The following is a description of a gene set: part of: Metabolism of proteins studied in species Homo sapiens Reactome Pathway: Post-translational protein modification After translation, many newly formed proteins undergo further covalent modifications that alter their functional properties. Modifications associated with protein localization include the attachment of oligosaccharide moieties to membrane-bound and secreted proteins (<b>N-linked</b> and <b>O-linked glycosylation</b>), the attachment of lipid (<b>RAB geranylgeranylation</b>) or glycolipid moieties (<b>GPI-anchored proteins</b>) that anchor proteins to cellular membranes, and the vitamin K-dependent attachment of carboxyl groups to glutamate residues. Modifications associated with functions of specific proteins include <b>gamma carboxylation</b> of clotting factors, <b>hypusine formation</b> on eukaryotic translation initiation factor 5A, conversion of a cysteine residue to formylglycine (<b>arylsulfatase activation</b>), methylation of lysine and arginine residues on non-histone proteins (<b>protein methylation</b>), <b>protein phosphorylation</b> by secretory pathway kinases, and <b>carboxyterminal modifications of tubulin</b> involving the addition of polyglutamate chains.<p><b>Protein ubiquitination</b> and <b>deubiquitination</b> play a major role in regulating protein stability and, together with <b>SUMOylation</b> and <b>neddylation</b>, can modulate protein function as well., and this is the list of marker genes: LGALS1, ALG1, RBX1, DCAF4, SCFD1, INO80E, IDE, H4C1, PSME3, L3MBTL2, DCUN1D3, JMJD6, COG3, RAB17, COPB1, RIOX1, ENAM, MUC12, RELA, LYPD8, PSMB10, FBXO40, SNX3, MUC5AC, UBE2D3, TUSC3, HDAC1, USP14, TRAPPC4, DNMT1, F9, FAM20A, PSMB7, MBD1, SATB2, PCNA, LMAN2, CISH, DCAF5, TUBB4B, SPSB1 (splA/ryanodine receptor domain and SOCS box containing 1), NEDD8, BLM, VCPKMT, PENK, PSMA5, LIPT2, TTLL6, DTL, BPIFB2, NUP35 (nucleoporin 35), MAN1A2, NOD2, RAB11B, AR, CNTN5, TRIM13, COPS8, RAB7B, RAB1A, ADAMTS4, AURKB, TUBB2B, B3GNT2, B3GNT8, CDC25A, USP17L4, PALB2, MYSM1, NSF, C1GALT1, CTR9, MAP3K7, ST8SIA4, RNF5 (ring finger protein 5), SBSPON, SCMH1, B3GALNT2, FBXL14, GOSR2, USP42, SPON1, C4A, ALPI, CUL7, CHML, ASB8, TUBA8, DCUN1D4, ST3GAL2, GALNT6, SPACA4, KLHL5, RAB29, PREB, KLHL41, TOP1, FEM1C, GPS1, FBXW8, FBXW9, OS9, SEM1, APOA2, ASB9, FBXW12, ADAMTS7, FBXL22, THBS1, FBXL19, UBA6, GALNT16, SKIC8, ADAMTS8, SVBP, RAB20, VNN1, HGS, FCSK, VDR, NUP214, ZNF350, KLHL22, FBXO2, PSMG3, STAMBP, PPARGC1A, CEACAM7, IL6, MUL1, TECTB, FBXW7 (F-box and WD repeat domain containing 7), DDX5, KLHL20, LYPD1, CUL4A, UBE2D2, PIAS3, SUMF2, YOD1, SEC31B, MBD6, DRG2, TP53BP1, RNF20, LY6H, UBE2D1, NUDT14, ADAMTSL1, PROS1, NOD1, GPAA1, BECN1, SEC23IP, INS, MBTPS1, NUP107, NPM1, FOXK1, SPTAN1, OTULIN, ST8SIA1 (ST8 alpha-N-acetyl-neuraminide alpha-2,8-sialyltransferase 1), PSMD3, TECTA, GANAB, U2AF2, SEH1L, SUMO1, RANBP2, HDAC7, ELOC, TUBA3C, FN3K, RAD52, NCOA1, FOXO4, NSMCE4A, RAET1L, B3GNT9, SENP5, MUC6, SERPIND1, NTNG1, DMP1, USP12, H2AC21, CST3, PSMB6, TAB1, PSMC1, TOPORS, NUP133, ALG2, ACTR8, UBXN7, USP34, APP, COMMD8, RNF40, ADAMTS15, SPTA1, PSMC2, TNFAIP3, FSTL3, NOTUM, ARFGAP3, USP11, COPS3, FBXO15, ALG10B, H2AC11, DYNC1LI2, RAB40C, ULBP2, MUCL1 (mucin like 1), RAB10, BMP15, STAMBPL1, PSMA7, GALNT11 (NCBI Gene Id 63917), MRTFA, FCGR3B, ADAMTS12, H2BC11, PSMD2, BTBD6, DYNC1I2, NUP210, TRIM25, UCHL1, B3GNT4, EDEM1, MUC17, TUBB4A (tubulin beta 4A class IVa), USP17L12, STT3A, TFAP2B, PUM2, HRC, FBXO31, CD59, FGG, NUB1, GFUS, UBE2V2, SKP1, PEX13, USP17L2, RAB41, ASGR2, TRIM28, TTLL5, GP2, HK1, ART4, ASB6, H2BC21, FBXO27, IKBKE, PIGF (phosphatidylinositol glycan anchor biosynthesis class F), DOHH, USP5, LYPD5, MCRS1, GCNT7, WDR5, PSME2, STAG1, MTA1, GPLD1, UHRF2, OTUD7B, PEX12, VNN2, COG6, COG4, MEN1, F7, RAB38, FBXO4, GPC3, MARCHF6, APLP2, RAB3A, ASB16, LY6D, FOLR1, RWDD3, RAB39A, SOCS5, FBXW11, EMID1, OSTC, RAB37, TUBAL3, RAB3C, SLC35A1 (NCBI Gene Id 10559), SMAD7, IZUMO1R, TEX101, TTLL10 (NCBI Gene Id 254173), DCTN4, EVA1A, SUMO2, RAB27B, ARSJ, ABRAXAS2, ST8SIA6, RPA1, GALNT17, ARF5, OST4 (oligosaccharyltransferase complex subunit 4, non-catalytic), ARRB1, SKP2, PEX2, SLC35C1, IGFBP7, MDC1, FGA, GALNT3, ST6GAL2, ST3GAL1, DCAF16, USP13, USP17L17, MITF, UBE2Z, KBTBD6, TNIP3, B4GALT6, SOCS6, GCNT4, PIGU, TFG, OTUD5, RAB33A, UBA2, TBC1D20, ARSL, F10, PSMF1, MUC7, PIGG, DCAF13, UBE2E1, NOP58, MUC3B, SEC22B, RECK, PEX14, MAN1A1, LSAMP, USP19, RNF168, ASB3, USP17L19, DPM2, STX5, TFAP2C, GALNTL6, UBD, SEC22A, H2BC17, ASGR1, TRAPPC2, POMP, GALNT14, ALPL, ATXN3, TRAPPC3, RNF144A, GOLGB1, CTBP1 (NCBI Gene Id 1487), ARSF, ACTR1A, DLAT, EID3, ADAMTS19, STT3B, RAB3D, RNF181, MUC20, USP37, CUL2, UBE2N, ANK1, UMOD, RAB13, SMAD2, RAB3B, RAB1B (RAB1B, member RAS oncogene family), NUCB1, GALNT9, USP22, GRIA1, UIMC1, GFPT1, MUC5B, EPAS1, DCTN1, LYPD4, ARSG, SPSB2, EEF1A1, DERL1, PSMC3, RAB4B, P4HB, DNMT3A, BST1, AGBL3, TDG, RAB21, UBE2T, RNF185, FBXO7, PSMB4, VHL, BARD1, B4GAT1, SPARCL1, H2BC3, ADRB2, FBXO22 (NCBI Gene Id 80234), MLEC, RABGGTB, CHGB, SEC24B, HDAC4, DCAF6, GLB1, THSD4, PMM2, XRCC4, OTUD3, MVD, CAPZA3, BTRC, SPP1, FBXO6, MUC2, C3, ADAMTS14, ABRAXAS1, RAB33B, RNF128, SERPINA10, NUP85, COG8, PROZ, PSCA, USP20, ADAMTS6, MMRN1, MDGA2, CD55, FBXL15, NUP43 (NCBI Gene Id 79700), QTGAL, FBXL4, TUBA3D, CHST10, CAPZB, ZBED1, UBE2G2, B3GNT6, PLET1, CLSPN, ADAMTSL2, LRR1, H2BC13, GALNT8, FUCA2, ALG12, TGOLN2, NRIP1, PPARA, UBA3, JOSD2, FBXL20 (F-box and leucine rich repeat protein 20), OBSL1, TPST2, GGCX, KLHL42, HLTF, CCP110, EIF5A2, PSMD1, COPS2, ASB5, USP17L24, SPSB3, PSMD13, RAD21, GALNT15, FUT8, EIF2AK2, PRSS23, NSMCE3, HLA-A, TMEM115, GAN, COMMD5, YKT6, FPGT, DNAJC24, CBX5, TUBB8B, CNIH2, NDUFAB1, THSD7A (NCBI Gene Id 23249), PSMA1, PIGP, B4GALT2, MAN2A2, RPL27A, DPH6, CDKN2A, LTBP1, TPGS1, CCNF, AXIN1, DYNC1LI1, MAN2A1, TRAF6, B4GALNT2, SERPINC1, TTLL1, USP30, NR3C1, FBXO41, DPH1, ST8SIA3, TRAPPC1, TUBB1, PSMC6, KNG1, RNF146, ST6GALNAC4, ST8SIA2, PGR, RAB34, H2AC14, RABGGTA, RENBP, F5, RAB23, COMMD7, ITIH2, TTLL12, ARSA, GCSH, NR1H4, PSMB1, TIMP1, XPC, COMMD10, NAPB, FBXL8 (NCBI Gene Id 55336), TNC, ALG11, CTSZ, IGFBP5, LMO7, WAC, RHOA, OPCML, H2AC18, FKRP, CALM1, POLB, DDOST, LAMB1, DCTN3, PIGC, KBTBD7, PSMA3, LAMC1, UBE2E3, ADAMTS16, SMURF2, SIN3A, PDIA3, ARF4, TULP4, RAD23B, ST6GALNAC6, H2AC6, TNKS, ACTR10, RNF135, DPM1, COPZ1, THBS2, RAB22A, H2BC18, NEGR1, DHPS, PIAS1, MYC, HDAC2, LHB, FBXW5, NUP155, NR1I2, FAM20C, BABAM1, AHSG, SEC24A (NCBI Gene Id 10802), B4GALT1, NR1H3, NLRP3, CAPZA1, RAB35, MDM4, NEU2, RAE1, FKTN, THSD7B, TGFBR1, USP17L5, ARRB2, THY1, WSB2, RAB11A, MGAT2, DCAF17, RPN2, SAE1, ALG5, LMAN2L, NUP62, RAB15, NR3C2 (NCBI Gene Id 4306), GALNT10, RXRA, TTLL9, TTLL2, CFP, BIRC5, IL33, NTNG2, RAB2B, USP17L8, ADAMTSL5, CBX8, TOMM70, ST3GAL5, USP16, PSMD11, APOB, NAPA, CHST4, SPON2, RTN4RL1, SEC24C, USP17L18, DDB1, CNIH3, RAB6B, PSMC5, SEC13, RCE1, RAB32, ASXL1, PRKDC, ST3GAL4, CDH2, ALG8, MDGA1, EDEM3 (NCBI Gene Id 87240), ASXL2, ETFBKMT, FURIN, CRPPA, PDIA6, GALNT5, GALNT12, WFS1, TP53, NAPG, PIGT, TOP2B, DOLK, MPDU1, METTL22, DNAJC3, BTBD1, H2BC15, ADAMTS13, INO80C, TUBA4A, HSPA8 (heat shock protein family A (Hsp70) member 8), ANO8, TF, TPST1, OTUB2, MAT2B, RAB27A, RAB40B, RAB9B, FBXO10, TTLL8, NUP205, SHISA5, TAF10, USP28, STS, USP17L13, DDA1, LIPT1, A4GNT, JMJD7, CDCA8, ADAMTS9, THRA, COG7, COG5, UBE2K, EDEM2, DPH2, ZRANB1, COPS7B (NCBI Gene Id 64708), ART3 (NCBI Gene Id 419), RPL8 (ribosomal protein L8), DRG1, RAB19, MGAT4A, PSMA4, GMPPB, DCAF7, COMMD9, SPTBN1, COPS5, RARA, DPM3, KAT2B, VWA1, NUP88, LYPD6B, PAF1, TUBB3, PIGW, B4GALT3, MBD5, TMED7, TRAPPC6A, ANK3, CSNK1D, INCENP, STAM2, NFE2L2, VASH2, USP2, PIGO (phosphatidylinositol glycan anchor biosynthesis class O), SMAD3, LYPD2, ASB11, CD109, DCTN6, FBXL12, SEC23A, BRCA1, HNRNPK, SMC5, AREG, DAXX, TMEM132A, CDK1, SOCS3, PRND, TUBA1C, ANKRD9, FUCA1 (NCBI Gene Id 2517), PSMA8, ADAMTS10, CAMKMT, INO80D, FOXK2, COPS6, CCNA2, ST6GALNAC1, USP3, BCL10 (BCL10 immune signaling adaptor), POFUT4, H2AC20, EEF1AKMT1, YY1, PSMD14 (proteasome 26S subunit, non-ATPase 14), USP10, RAB5C, SEL1L, DCUN1D2, WDR20, H2BC14, USP17L21, WDTC1, RXYLT1, SP3, PTEN, GATA3, KLHL13, H2AC25 (H2A clustered histone 25), NAGK, UBE2M, ADAMTS20, NRN1L, DPH3, GOLM1, SQSTM1, RORA (RAR related orphan receptor A), RAB7A, TMED2, TPGS2, NUP160, GNPNAT1, STX17, SYVN1 (NCBI Gene Id 84447), SDC2, MANEA (mannosidase endo-alpha), VDAC2, DHDDS, POMGNT2, KLHL9, ADAM10, BGLAP, COL7A1, CCN1, NANS, DCTN2 (dynactin subunit 2), PSME1, EEF2KMT, USP24, COPB2, PSMG1, NUP37, AMELX, RCN1, NUP93, COPG2, RHOT1, USP17L10, PSMB8, ENGASE, ICMT, FBXL13, PIGB, NUP42, ASB10, MUC13, EEF1AKMT2, MCFD2, EEF2, CASP8AP2, UBC, UBE2S, TRAPPC5, CCDC22, ARF1, LMAN1L, RIOX2, RBBP7, MGAT4C, GALNT2, OTUD7A, OTOA, CNTN4 (contactin 4), FEM1A, COG2, RNF103, CETN2, BRCC3, ST6GALNAC2, KDM8, AMFR, IFIH1, CCDC8, DCUN1D1, RNF152, GNE, DCAF11, UBE2W (ubiquitin conjugating enzyme E2 W), TTLL11, UBE2H, PSMD9, TAF9B, KCTD7, RNF139, CUL4B, SAFB, SHPRH, DDB2 (damage specific DNA binding protein 2), MEPE, RAB43, ASPH, NDC1, SIAH2, MATN3, LY6E, PSMD8, AMDHD2, DPAGT1, GORASP1, ST6GAL1, CREBBP, CUL9, ST3GAL3, COPA, INO80, MUC1, CP, NEU1, JOSD1, RING1, KLHL25 (NCBI Gene Id 64410), VCP, COPS4, TRAPPC9, TRAF3, NGLY1, RPS23, ARSH, NEU3, SLC17A5, PIGV, GOSR1, DCUN1D5, C1GALT1C1, H2AC12, RAB26 (NCBI Gene Id 25837), COP1, SSPOP, NFKB2, PRMT3, SEMA5B, ADAMTS1, F2, RBBP5, RNF2, COMMD4, RAB14, GMPPA, RAB8A, MUC3A, TADA3, NANP, PRKCSH, NFU1, USP8, CYLD, UAP1, POMK, UBE2J2, RAD23A, KIN, ADAMTSL4, RAB18, CUL5, PRSS41, SMC6, MELTF, FBXL16, FBXO32, HNRNPC (heterogeneous nuclear ribonucleoprotein C), PIGN (NCBI Gene Id 23556), CMAS, H2BC1, PCSK9, RANGAP1, SOCS2, PIGQ, ZBTB16, RAB36, ALG9 (NCBI Gene Id 79796), DPH7, TNIP1, BIRC3, TOMM20, RAB6A, CAND1, CALR, B4GALT4 (beta-1,4-galactosyltransferase 4), ZC3H15, CHRDL1, MAVS, RPS2, PSMA6, PHC1, TPR, TTLL7, H2BC9, GOLGA2, MFGE8, SEC31A, NCOA2, KLHL21, PHC3, DCTN5, ADAMTSL3, LY6K, US11, NPL, ARSB, GALNTL5, UBE2A, SRD5A3, RTF1, USP17L15, LY6G6C, SEC22C, BMP4, STC2, DYNC1I1, KBTBD8, POFUT2, FBN1, NTM, CNIH1, KLHL2, UBA1, TUBA1A, PRKN, FBXO30, AGBL5, ETF1 (NCBI Gene Id 9190), PSMA2, ARSI, TTL, TUBA4B, TUBA3E, PGM3, PIGL, PSMB11, ANKRD28, AMTN, BET1L, ST3GAL6, POM121C, MAN1B1, RAD18, OTUB1, DPH5, SPP2, CBX4, IGFBP3, H2BC4, RAB31, TGFA, CALU, RNF123, ARFGAP1, MUC15, ALG13, MUC19, SMC3, HLA-B, RAB40A, B3GNT7, PTRH2, GMDS, ASB1, FBXL18, IKBKG, INO80B, USP17L3, RAB12, PRSS21, DYNC1H1, MIA3, PSMB2, PPP6R1 (protein phosphatase 6 regulatory subunit 1), NPLOC4, PLAUR, TOP2A, FBXL21P, ADRM1 (NCBI Gene Id 11047), ST6GALNAC3, SERPINA1, TMEM258, APOE, PIGZ, SCG2, F8, USP18, ARF3, ASB17, PSMD7, FBXL7, H2BC26, FBXO9, BABAM2, UBB, HSP90B1, VASH1, RIPK1, EP300, TGFBR2, SUZ12, RCCD1, POM121, H2AC4, XPNPEP2 (NCBI Gene Id 7512), PIGS, ING2, PSMG4, TUBB2A (NCBI Gene Id 92919), NUP50, KLHL3, NEU4, PMM1 (phosphomannomutase 1), NEURL2, THRB, KBTBD13, MSLN, TRAF2, EIF5A, TRRAP (NCBI Gene Id 8295), ELOB, RAB24, ASB14, FBXW10, CBX2, ESR1, COPE, VCAN, SELENOS, PARK7, AGBL2, HCFC1, DAG1, APOA1, X, PNPLA2, TTLL3, POMT1, UBE2I, ASB4, MAN1C1, USP26 (NCBI Gene Id 83844), SPRN, PIAS4, DBT, UBE2G1, USP25, PSMD4, MUC16, HIPK2, COPS7A, UFD1, H2AC1, OGT (NCBI Gene Id 8473), POFUT3, PSMD6, PEX5, PAAF1, CTSA, GAS6, LRRC49, TRAPPC2L, AGTPBP1, NUP58, ASB12, ASB7, PROC, RAB30, FUT3, SCG3, SMAD4, UBE2L3, FGF23, UGGT1, FSTL1, LRRC41 (leucine rich repeat containing 41), TRAPPC6B, VDAC3, APC, PML, ASB18, KCTD6, UBE2B (ubiquitin conjugating enzyme E2 B), AGBL4 (AGBL carboxypeptidase 4), SPTBN5, RAB39B, DAD1, LYPD3, FBXW2, USP17L20, SEC16A, PHC2, SLC35A4, KLHL11, PIGM, BIRC2, USP15, CNTN3 (NCBI Gene Id 57632), TMED3, ST8SIA5, CGA, PIGA, NAE1, PSMB3, THSD1, KAT2A, SPTBN4, DOLPP1, B3GNT3, PPARG, BMI1, BAP1, RPS6, SUMO3, PIGH, LIAS, QSOX1, ANK2, GALNT18, MPI, SPTB, PCGF2, TUBA1B, APOL1, ADAMTS18, STAM, DHRSX, GFPT2, FOLR2, ASB2, RAB42, LY6G6D, NRN1, PSMB5, CDKN1A, NUP98, AFP, COMMD3, VDAC1, RAB4A, CFTR, PTP4A2, RAB25, WDR48, CPM, H2AC7, IGFBP1, PIAS2, CKAP4, H2BC12, WSB1, SUMF1, LARGE1, DYNLL1, APOA5, KEAP1, B3GNT5, CDC73, ALB, NFRKB, TNKS2, PSMD10, PPP6R3, DYNLL2, SPSB4, MGAT1, NR5A1, UBE2R2, HIF3A, FN3KRP, B4GALT5, ARCN1, USP4, TNIP2, SUDS3, FOXL2, SPTBN2, MDM2, SENP8, COPZ2, MGAT5B (alpha-1,6-mannosylglycoprotein 6-beta-N-acetylglucosaminyltransferase B), PSME4, DNMT3B, MUC21, ARSK, ETFB, MGAT4B, ZNF131, PPP6C, KDELR2, ACTB, NICN1, NR4A2, DPP3 (NCBI Gene Id 10072), GALNT7, UBE2F, TRIM4, ALG14, HIF1A, GCNT3, TMED9 (transmembrane p24 trafficking protein 9), COMMD1, PARP1, MMRN2, TRAPPC10, CDC34, KTN1, BET1, LMAN1, NR1H2, POMGNT1, ATXN3L, ASB13, NUP188, RAB8B, CCNA1, LARGE2, USP49, FBXL5, POMT2, ADAMTS5, TUBB8 (NCBI Gene Id 347688), USP21, RFT1 (RFT1 homolog), NUP153, CUL3, USP47, TMED10, GALNT1 (polypeptide N-acetylgalactosaminyltransferase 1), KDELR3, KDM1B, CD52, JMJD4, ARSD, RAB5B, RAB44, FBXL3, PIGX (NCBI Gene Id 54965), USP48, TTLL4, AGBL1, ADAMTS2, CAPZA2, DDX17, UCHL5, PEX10, MIA2, ST6GALNAC5, RTN4RL2, RIGI, UBE2C (NCBI Gene Id 11065), TTLL13, USP17L22, RAB9A, USP17L1, AXIN2, RPN1, TUBB6, MOGS, ACTL6A, AMBN, RRAGA, ACTR5, RWDD1, GPIHBP1, VCPIP1, FBXO21, SEMA5A, TGFB1, SP100, GCNT1, SEC24D, GBF1, COG1, UBXN1, MXRA8, SATB1, SENP2, ALPG, CSF1, H2BC5, SMAD1 (SMAD family member 1), LAMB2, VGF, UGGT2, USP9X, SENP1, HIC1 (HIC ZBTB transcriptional repressor 1, NCBI Gene Id 3090), FN1, GALNT4, USP44, AURKA, AMER1, ALG3, STAG2, SEC16B (NCBI Gene Id 89866), NUS1, CDC20, UBE2Q2, CUL1, MGAT3, NSMCE2, NR5A2, CANX, RAB2A, MGAT5, NCOR2, MAGT1, FBXO17, TRIM27, DERL2, WRN (WRN RecQ like helicase), USP17L11, MUC4, ERCC8, ALG6, LEO1, KDELR1, RUVBL1, AAAS (NCBI Gene Id 8086), ADAMTS17, PSMC4, DLST, DCAF8, ADAMTS3, USP7, PSMB9, USP33, CHM, HERC2, FUOM, FBXO44, FEM1B (NCBI Gene Id 23374), TMEM129, CEACAM5, COMMD2, FDX1, IGFBP4, UBA52, PSMG2, OGFOD1, NSMCE1, COMMD6, SAR1B (NCBI Gene Id 56680), TFAP2A, CTSC, COPG1, PIGK, RNF7, USO1, PGAP1, PSMD12, FKBP8, RAET1G, METTL21A (NCBI Gene Id 151194), NFKBIA, PSMD5, NUP54, ATXN7, ASB15, FBXW4, PIGY (phosphatidylinositol glycan anchor biosynthesis class Y), ALG10, TADA2B, CHD3, RAB5A, GALNT13, B3GLCT, TFPT, UCHL3, RIPK2, RPS27A, DCAF10, FBXO11, SMC1A, NR2C1, CHST8, ARFGAP2